Given this list of marker genes EYA1, BCL2, MCL1, PRDX2, UNC5B, AKT1, COL2A1, HSPA1B, C8orf44-SGK3, IL7, CTNNA1, PF4, CSF2, NRG1, FYN, GATA1, HSPA1A, GFRAL, MAPK7, SNAI2, RIPK1, TERT, KLF4, EYA2, FGF10, CX3CL1, TNF, IL1A, EYA3, IL1B, EYA4, IFI6, MAP2K5, SGK3, BCL2L1, STRADB, GDNF, here is a description of the gene set: Human Gene Set: GOBP_NEGATIVE_REGULATION_OF_SIGNAL_TRANSDUCTION_IN_ABSENCE_OF_LIGAND species: Homo sapiens Any process that stops, prevents or reduces the frequency, rate or extent of signal transduction in absence of ligand.